Given this list of marker genes Avpr1a (NCBI Gene Id 54140), Nlrp6, Avpr1b, Npsr1, Oxtr, Inpp5k, Avpr2, here is a description of the gene set: species: Mus musculus Mouse Gene Set: GOMF_VASOPRESSIN_RECEPTOR_ACTIVITY Combining with vasopressin to initiate a change in cell activity.